The following is a description of a gene set: species: Homo sapiens Reactome Pathway: Gamma-carboxylation of protein precursors Gamma-carboxylation of a cluster of glutamate residues near the amino termini of thrombin, factor VII, factor IX, factor X, protein C, protein S, protein Z, and Gas 6 is required for these proteins to bind Ca++ and function efficiently in blood clotting. A single enzyme, vitamin K-dependent gamma-carboxylase, catalyzes the gamma-carboxylation of all eight proteins involved in clotting. In the carboxylation reaction, the enzyme binds its substrate protein via a sequence motif on the amino terminal side of the glutamate residues to be carboxylated, then processively carboxylates all glutamates in the cluster before releasing the substrate. The reaction occurs in the endoplasmic reticulum. part of: Gamma-carboxylation, transport, and amino-terminal cleavage of proteins, and this is the list of marker genes: PROC, F7, PROZ, GAS6, F9, GGCX, F10, BGLAP, F2, PROS1